Given this list of marker genes Sumo1, Galr2, Lrrc26, Cacna1d, Kcnab1, Casq2, Nr3c2, Akap9, Abcc9, Neto1, Actn2, Kcne2, Wwp2, Crbn, Lrrc52, Kcnrg (potassium channel regulator), Kcnj1, Nppa, Agrn (agrin), Gal, Grp, Lrrc38, Nedd4l, Ywhae, Cav1, Fhl1, Nedd4, Kcne3, Stk39, Kcne1, Kcnq1, Vamp2, Lrrc55, Atp1b3, Oxsr1, Rnf207, Atp1b2, Akap6, Atp1b1, Itgb1, Ank3, Akap7, Ank2, here is a description of the gene set: Any process that modulates the frequency, rate or extent of potassium ion transmembrane transporter activity. Mouse Gene Set: GOBP_REGULATION_OF_POTASSIUM_ION_TRANSMEMBRANE_TRANSPORTER_ACTIVITY studied in species Mus musculus